The following is a description of a gene set: Reactome Pathway: ADORA2B mediated anti-inflammatory cytokines production part of: Anti-inflammatory response favouring Leishmania parasite infection The natural ligand for adenosine receptor A2B (ADORA2B) is extracellular adenosine (Ad-Rib), formed from the reduction of ATP by ENTDPases. ATP enters the extracellular space in response to parasite infection, tissue injury, apoptosis amongst other stress factors and has chemotactic and excitatory effects (Cekic et al.2016).<br><br>The reduction of ATP to Ade Rib is thought to be a regulatory mechanism by which the synthesis of anti inflammatory cytokines is induced. In addition, killing mechanisms are switched off. Accordingly, increased expression of ADORA2B in monocytes correlates with higher Leishmania donovani parasites loads alongside increment of IL10 production. Exacerbation of lesion development in L. amazonensis infected mice also correlated with high amounts of Ade Rib. species: Homo sapiens, and this is the list of marker genes: GNB2, IL6, GNG4, ADCY2, ADCY7, GNG11, ADCY3, ADCY5, GNG13, PRKAR1B, GNG12, GNG7, ADCY4, GNG3, GNB3, GNAT3, ADORA2B, ADCY1, GNAZ, PRKX, CREB1, PRKAR2B, GNGT2, PRKACG, GNB1, GNAI1, PRKACA, PRKAR2A, PRKAR1A, ADCY6, GNG8, GNB4, GNG2, GNAI3 (G protein subunit alpha i3), ADCY9, PRKACB, GNB5, GNG5, GNGT1, ADCY8, GNG10, GNAI2, GNAS